The following is a description of a gene set: Catalysis of the movement of phosphatidylserine from the exoplasmic to the cytosolic leaflet of a membrane, using energy from the hydrolysis of ATP. Human Gene Set: GOMF_PHOSPHATIDYLSERINE_FLIPPASE_ACTIVITY studied in species Homo sapiens, and this is the list of marker genes: ATP8B1, ATP8A2, ATP11A, ATP11C, ATP8A1